Given this list of marker genes Fxyd3, Fxyd4, Abcc9, Nos1, Prkaca, Sri, Atp2b4, Atp1a3, Camk2d, Atp1b3, Slc8a3, Tnni3, Itpr2, Ryr3, Dmpk, Fxyd2 (FXYD domain-containing ion transport regulator 2), Atp2a2, Stim1, Calm1, Slc8a2, Trpc1, Pln, Atp2a3, Calm2, Atp1b1, Fxyd1, Casq1 (NCBI Gene Id 12372), Calm3, Camk2b (calcium/calmodulin-dependent protein kinase II, beta), Atp1a4, Atp2b2, Ahcyl1, Asph, Atp2b3, Ryr1, Camk2a, Slc8a1, Casq2, Itpr1, Atp1a2, Atp1b2, Atp2a1, Fxyd7 (NCBI Gene Id 68670), Kcnj11, Itpr3, Fxyd6, Atp2b1, Ryr2, Atp1a1, Camk2g, Fkbp1b, Trdn, here is a description of the gene set: studied in species Mus musculus Ion homeostasis Mouse Gene Set: REACTOME_ION_HOMEOSTASIS